The following is a description of a gene set: species: Homo sapiens Human Gene Set: GSE21670_UNTREATED_VS_IL6_TREATED_CD4_TCELL_UP from publication Durant L, Watford WT, Ramos HL, Laurence A, Vahedi G, Wei L, Takahashi H, Sun HW, Kanno Y, Powrie F, O'Shea JJ (PMID 20493732) STAT3, an essential transcription factor with pleiotropic functions, plays critical roles in the pathogenesis of autoimmunity. Despite recent data linking STAT3 with inflammatory bowel disease, exactly how it contributes to chronic intestinal inflammation is not known. Using a T cell transfer model of colitis we found that STAT3 expression in T cells was essential for the induction of both colitis and systemic inflammation. STAT3 was critical in modulating the balance of T helper 17 (Th17) and regulatory T (Treg) cells, as well as in promoting CD4+ T cell proliferation. We used chromatin immunoprecipitation and massive parallel sequencing (ChIP-Seq) to define the genome-wide targets of STAT3 in CD4+ T cells. We found that STAT3 bound to multiple genes involved in Th17 cell differentiation, cell activation, proliferation and survival, regulating both expression and epigenetic modifications. Thus, STAT3 orchestrates multiple critical aspects of T cell function in inflammation and homeostasis. Genes up-regulated in CD4 T cells: medium versus IL6., and this is the list of marker genes: WIPI1, CCSER2, BATF, CDIPT, CIPC, CD72, POLR2J, STARD10, AUP1, ENKD1, CNTROB, SOCS1, PLXNA3, CMTM3, HPD, FBXO5, ASS1, PLEKHF1, TNFAIP3, GBF1, PRPSAP1, PUM1, KRTAP13-3, MIR600HG, IRF2BP2, PPP2R5D, MED25, DUSP16, TMEM43, ZNF232, PEF1, EDRF1-DT, TMUB1, PTGES2, TMEM143, PPP2R5C, TOMM34, UNC13D, CDH1, AMPD2, BAIAP2, CLPTM1L, RANGAP1, HLA-A, HEXD, COQ4, SIK1, CHUK, DNAJB2, DLAT, MCOLN2, CXCR4, NEK7, MAPKAPK3, SMPD2, TSSC4 (NCBI Gene Id 10078), CSRP1, AKAP13, COG5, NCKAP1, TOX, TPM4, SEMA5B (NCBI Gene Id 54437), INTS11, C2orf68, ANKRD36BP1, NXF1, SDHD, DUSP4, NBEAL2, NR3C1, IRAK1, SEMA5A, PPP1R16B, CLEC14A, LINC01011, RAB9A, ATG9A, GOLPH3, ZBTB21, TRIM68, STK24, MYO1D, HDAC4, SLC37A4, TOP1MT, SEMA4D, OXA1L, POU3F3, IL17RB, LONP1, UBTD2, RGS2, MUSTN1, ILVBL, ZAP70, LINC00905, ING1, SNORA70D (NCBI Gene Id 100379141), SPMIP4, ZNF663P, ITPK1, AP2M1, GSS, DVL3, CCNI, RITA1, PTPRD, PREB, MT1HL1, TIGIT, POLDIP3, HS6ST1, KIF1C, NCOA1, MSL2, SLC25A24 (NCBI Gene Id 92093), QSOX2, ABHD15, USP31, AKT2 (NCBI Gene Id 208), TREML3P, OAF, KAT2A, TICRR, SMNDC1, CNPPD1, INTS1, ZNF672, APP, ZSWIM8, PDCD6P1, SPRR3, ADRA1D, PPP1R35, KCNB1, URAD, JAK1, SNORA6, CNOT1, TRIM14, SLC29A4, STK36, STARD3, MFHAS1, SLC25A11, INO80E, GGA3, MYO5B, PLEKHG2, AP4B1, SCG5, TPM3P9, BCORL1, SH2D2A, LRRN4, YIPF3, MZB1, PPP1R37, PLP2 (NCBI Gene Id 5355), PEX16, ZNF683, TENT5C, ANKLE2, FAM219A, PROKR2, UBQLN4, MCF2L2, CDX2, AGAP3, CAPN1, TMSB15A, TNP1, KLF16, JAZF1, CCDC50, DDIT4, ZCCHC10, AGPAT1, APOBEC3A, RNPEPL1, ARMC7, CCL13, CCDC3, IL2RB, MIR29B1, PFKFB3, NUDT9, MXD4, RASA3, IP6K1, SLC4A2, CIMAP1A, SLC35A2, PRR5L, SPATA6, EAF1, PHF13